The following is a description of a gene set: Mouse Gene Set: GOMF_OXIDOREDUCTASE_ACTIVITY_ACTING_ON_NAD_P_H_OXYGEN_AS_ACCEPTOR Catalysis of an oxidation-reduction (redox) reaction in which NADH or NADPH acts as a hydrogen or electron donor and reduces an oxygen molecule. species: Mus musculus, and this is the list of marker genes: Pdgfb, Mical2, Ncf1, Nox1, Nox3, Ncf2, Noxa1, Mical1, Nox4, Cybb, Duox1, Fmo5, Aifm1 (apoptosis-inducing factor, mitochondrion-associated 1), Noxo1, Duox2, Cyb5r4, Sh3pxd2b, Txnrd1, Ncf4, Sh3pxd2a, Cyba, Kmo (NCBI Gene Id 98256)